The following is a description of a gene set: species: Homo sapiens from publication Hay SB, Ferchen K, Chetal K, Grimes HL, Salomonis N (PMID 30243574) Human Gene Set: HAY_BONE_MARROW_CD34_POS_PRE_B, and this is the list of marker genes: TM7SF2, BEST3, BAZ2A, ADAM23, NEIL1, NIBAN3, LINC01215, RB1, CFAP251, STIM2, TMEM243, STARD4-AS1, DTX1, NSMCE1, FAM3B, APBB2, SYK, PLEKHA2, KIN, HRK, RIMS3, LAMA5, DDX54, FMO1, BCL7A, BACH2, CFAP73, MPZL1 (NCBI Gene Id 9019), ERP29, SHOX2, BTBD3, WASF1, CCDC69, EIF3F, TCL1B, PPP1R14A, ROR1, SOX4, PCDH9, NSUN7, MIR181A1HG (NCBI Gene Id 100131234), REPIN1, AEBP1, ACSM3, LINC03066, TMEM38A, H2BC8, CEMIP, RUBCNL, TMEM131L, MRO, EFHC1, PLG, AFF3, ENSG00000223881, BTK, CDC40, C7orf50, SBSPON (NCBI Gene Id 157869), NOXA1, LDLRAD4, RASAL1, MYO1C, LINC02227, GSDME, DNMT3B, FOXD3-AS1, IRF4, UBXN1, ENTPD8, AMBP, BMP3, LIMD2 (NCBI Gene Id 80774), HIP1, H1-2, CCDC112, KIF12, SNHG7, CDC25B, CD38, SYF2, TBC1D1, TCL1A, TRAM1, TRABD, C16orf74 (chromosome 16 open reading frame 74), SYNE3-AS1, TAX1BP3, CECR2, DYM-AS1 (NCBI Gene Id 100129878), KLHL14, RAPGEF5, KANK2, CSNK1E, RCSD1, CDHR3, PAX5, ABHD15, CD79B, CCDC191